The following is a description of a gene set: Genes predicted to be targets of miRBase v22 microRNA mmu_miR_148a_3p, mmu_miR_148b_3p, mmu_miR_152_3p in miRDB v6.0 with MirTarget v4 prediction scores > 80 (high confidence targets). Mouse Gene Set: MIR_148A_3P_MIR_148B_3P_MIR_152_3P from publication Chen Y, Wang X (PMID 31504780) species: Mus musculus, and this is the list of marker genes: Yy2, Phactr2, Lbr, Serpine1, Prkcz, Med12l, Prickle2, Smim12, Rigi, Lrch1, Mllt10, Ube2d1, Zfyve26, Sik1, Foxf1, Ago4, Bach2, Gm10439, Arfip1, Maf1, Arhgap21, Macir, Hmg20a, Ubap2l (NCBI Gene Id 97055), Slc24a2, Gpatch8, Plaa, Ajuba, Luzp4, Tgif2 (TGFB-induced factor homeobox 2), Tomm70a, Rab14 (NCBI Gene Id 99047), B4galt5, Abca1, Gap43, Rbm24, Gm15127, Eml2, Stox2, Pi4k2a, Cs, Tnrc6c, St18, Sgms1, Gm15080, Gm15091, Fbn1, Ott, Atp7a (NCBI Gene Id 51824), Gpkow, Itpk1, Zcchc2, Oxsr1, Cdk19, Nr2c2ap, Pnpla6, Cnot6, Slc24a3, Nol4l, Elavl4, Cdk5r1, Ncoa1, Sgcb, Lrp2, Ctxn3, Amot, Rfx7, Dicer1, Sos2, Adam10, Gpcpd1, Epn2, Snn, Kdm7a, Runx2, Tgfa, Nog, Stam, St8sia3, D5Ertd579e (NCBI Gene Id 77811), Psmb6, Ccnf, C1galt1, Tmem266, Nrarp, Nat14, Acyp2, Usp33, Srsf11, Szrd1, Marchf2, Mlst8, Kat7, Hbs1l, Itga5, Hecw2, Gm15107, Stt3a, Inhbb, Mmd, Slco4a1, Abcb7, Mospd1, Elavl2, Tmem9b, Smad2, Ism1, Ago2, Arap2, Itga9, S1pr1, Zdhhc17 (zinc finger, DHHC domain containing 17), Usp7, Itsn2, Vcf1, Cdkn1b, Pou3f2, Stk38l, Hivep1, Btbd3, Rtca, Esr1, Ppp1r10, Prkaa1, Ino80, Slc25a44, Phf24, Cntn4, Meox2, Klf6, Arpp19, Trak2, Zbtb18, Zfp804a, Itga11, Pik3r3, Fcho2, Wnt10b, Cxcl13, Rmnd5a, Tmod1, Slc35d1, Kmt2a, Gm15114, Fbxl19, Cul5, Mbip, Gpr183 (G protein-coupled receptor 183), Ube2d3, Gadd45a, Rph3al, Cand1, Robo2, Osbpl11, Ube4b, Ythdc2 (NCBI Gene Id 70219), Idi1, Slc25a53, Esrrg, Ssr1, Arrdc3, Mllt6, Pdk4, Oas1c, Errfi1, Map3k9, Ralbp1, Robo1, Ddx6, Camsap1, Hs3st1, Gm15093, Mdfic, Cep350, Col4a1, Vgll1, Ppp6r1, Fam234a, Lgalsl, Ago1, Jarid2, Phf3, Fgf12, Arl6ip1, Amacr, Tmem54, Bmp2k, Bcl2l11, Canx, Ucp3, Stard13, Lrrc41, Atp2b4, Fut9, Cyp4a14, Spty2d1, Gm15085, Atxn1, Gm15097, Rictor, Nptx1, Neurl4, Rab34, Actr3b, Macroh2a1, Tbl1xr1, Jph3, Npepl1, Mtif3, Csf1, Fmr1 (NCBI Gene Id 207836), Atp8a1, Nrp1, Dpp4, Znrf1, Gpm6a, Ing2 (NCBI Gene Id 69260), Usp32 (ubiquitin specific peptidase 32), Skp1, Ywhab (NCBI Gene Id 80438), Barhl2, Usp8, Etl4, Snx27, Dcun1d3, Rph3a (rabphilin 3A), Kcna1, Dcp2, Cbll1, Ube3b, Rgma, Ptpn14, Manba, Otud4, Nptn, Mtmr12, Ltf, Btaf1, Dgcr8, Nova1, Hoxc8, Mnt, Atg14, Dnmt1, Adamts15, Dmxl1, Mafb, Rnf38, Cblb, Eogt, Cerk, Rassf8 (NCBI Gene Id 71323), Mrpl19, Akap1, Cdk8, Klf4, Usp48 (ubiquitin specific peptidase 48), Kcnj8, Relch, Cyth3, Jmy, Agfg1, Tnpo1, Slain2, Med27, Tnrc6a, Hepacam2, Naaladl2, Mpped2 (NCBI Gene Id 99312)